Given this list of marker genes Dpp4, Prss16, Dpp7, Dpp9, Dpp6, Fap, Dpp10, Prcp, Dpp3, Ctsc, Dpp8, here is a description of the gene set: Mouse Gene Set: GOMF_DIPEPTIDYL_PEPTIDASE_ACTIVITY studied in species Mus musculus Catalysis of the hydrolysis of N-terminal dipeptides from a polypeptide chain.